The following is a description of a gene set: species: Mus musculus Mouse Gene Set: GOBP_NEGATIVE_REGULATION_OF_PERK_MEDIATED_UNFOLDED_PROTEIN_RESPONSE Any process that stops, prevents or reduces the frequency, rate or extent of the PERK-mediated unfolded protein response., and this is the list of marker genes: Ddrgk1, Atad3a, Abca7, Akt1 (NCBI Gene Id 268604), Hspa5, Nck1, Akt3, Igtp, Ptpn1, Akt2, Nck2